The following is a description of a gene set: species: Mus musculus Mouse Gene Set: MIR_532_3P from publication Chen Y, Wang X (PMID 31504780) Genes predicted to be targets of miRBase v22 microRNA mmu_miR_532_3p in miRDB v6.0 with MirTarget v4 prediction scores > 80 (high confidence targets)., and this is the list of marker genes: Ino80d, Ccin, Gopc, Gabrb3, Ccdc181, Cyria (NCBI Gene Id 76820), Pik3cb, Myb, Tspoap1, Hes5, Kif7, Trpm2, Pwp2, Or13e8, Bet1, Scn2b, Elapor2, Hmga2, Cdhr3, Vash1, Dipk2b (NCBI Gene Id 75905), Cab39, Tnfsf8, Eml2, Lpgat1, Chfr, Alcam, Lrfn2, Camkv, Gm3336, Nek9, Mtch2, Snx11, Npdc1, Pten, Adamts17, Fam171a2 (NCBI Gene Id 217219), Scyl2, Cyb561d1, Sp5, Iqcb1 (NCBI Gene Id 328669), Exoc6b, Ndc1, Hoxb2, Mbtps1, Tomm22, Acss3, Arhgdib, Krtap6-1, Wnt2b (NCBI Gene Id 22414), Treml4, Mark3, Mc3r, Gdap1l1, Srprb, Eif4g3, Abcf3, Efna5 (ephrin A5), Inpp5a, Mmp16, Sumo1, Tmem252, Hic2, Clmp, Arl6ip1, Cyth1, Mrgpre